The following is a description of a gene set: species: Homo sapiens Kallmann syndrome Human Gene Set: WP_KALLMANN_SYNDROME, and this is the list of marker genes: OTX2, NEUROG1, GNRH1, MAP2K2, PROKR2, ANOS1, ASCL1, OLIG2, FGFR1, PIK3CA, PROK2, SOX10, SEMA3E, LHB, TMEM98, AKT1, PTPN11, PLXND1, CHD7, GRB2, MYRF, FRS2, FGF8, MAPK1